Given this list of marker genes HDAC1, FOXP1, FOXH1, IGF1, SIRT1, KANK2, VPS11, CRY1, BRCA1, CNOT9 (NCBI Gene Id 9125), NODAL, CLOCK, NCOR2, TCF7L2, STRN3, CNOT1, PER1, NR0B1, DAB2, ISL1, TP63, PIAS2, ZNF366, PHB2, HEYL, SMARCA4, CNOT2, ZBTB7A, SFRP1, CYP7B1, LBH, CREBRF, TCF21, PHB1, VPS18, RHOA, BMAL1, CRY2, CALR, CDK12, NCOR1, HMGA2, here is a description of the gene set: Human Gene Set: GOBP_NEGATIVE_REGULATION_OF_INTRACELLULAR_STEROID_HORMONE_RECEPTOR_SIGNALING_PATHWAY Any process that stops, prevents, or reduces the frequency, rate or extent of the activity of any intracellular steroid hormone receptor signaling pathway. species: Homo sapiens